The following is a description of a gene set: studied in species Homo sapiens from publication Liberzon A, Birger C, Thorvaldsdóttir H, Ghandi M, Mesirov JP, Tamayo P (PMID 26771021) Human Gene Set: HALLMARK_APICAL_SURFACE Genes encoding proteins over-represented on the apical surface of epithelial cells, e.g., important for cell polarity (apical area)., and this is the list of marker genes: HSPB1, EPHB4, GAS1, AFAP1L2, NTNG1, PLAUR, ATP8B1, BRCA1, NCOA6, EFNA5, GSTM3, AKAP7, THY1, ADIPOR2, APP, MDGA1, ADAM10, GATA3, SLC2A4, LYPD3, FLOT2, ATP6V0A4, IL2RG, GHRL, MAL, RTN4RL1, B4GALT1, PCSK9, CRYBG1, IL2RB, CX3CL1, SULF2, SCUBE1, SRPX, RHCG (Rh family C glycoprotein), SHROOM2, DCBLD2, SLC22A12, LYN, TMEM8B, SLC34A3, PKHD1, CD160, CROCC